Given this list of marker genes USH2A, ZNRF2, PF4V1, PDE4D, DCDC2, CYP2C19, ETS1, NEDD9, MFN2, ADGRL3, ZFYVE28, PPP6R2, BTBD7, C19orf12, LRRC4, PML, MCC, SCN8A, KIF21A, CUL5, LIX1, ZBTB21, E2F6 (NCBI Gene Id 1876), KDELR2, ZBTB20, RAB11FIP2, LMBRD1, LSM8, SKIC3, TMEM132B, ATXN7L1, RBM24, USP42, ASB4, GOLGA4, MBD1, ZNF704, KMT2A, STC2, TNPO1, RINT1, DCUN1D4, TSPAN12, HNRNPF, FRY, ANKRD6, FRS2, RAB3GAP2, NSMAF, TMEM176B, CDKL4, RORA, MYORG, APPL1, SRSF11, ZNF571, BCL11A, PPM1E, SPINT1, GORAB, MAPK9, KHDRBS2, MAP1B, DPYD, DICER1, SSH1, FNIP1, ITGB1BP1, LRRN1, DLL1, RAB33A, RHBDL2, ASH1L, CD1E, KDM5B, CRYBG1, ELK4, ETNK1, BTN3A2, FGFR2, ARMCX3, ZBTB18, BTN3A1, ATP1B2, DPY19L2, UBP1, ANKIB1, TNRC6B, SLITRK4, DCTN6, WDR20, CBFB, YTHDF1, RNF38, JADE1, CDYL2, LDLRAD4, DLEU7, ZNF407, MEF2C, MINDY2, AMOT, PRKACB, GAB1, GPRASP2, CHD6, CREB1, MED26, NEDD4, PJA2, RNF19A, RLN1, DYNC1LI2, RBCK1, MIEF1, CNOT9, PRKAG2, TGFBR3, TMEM74, ZBED1, USP10, ABCB5, DCBLD2, RUBCN, CDK6, TMEM30A, RNMT, NF1, CAB39, TARDBP, KLHL9, VWA8, SMPDL3A, PPP6C, PDE3B, GPCPD1, HSF5, TBKBP1, TENM3, DCDC1, SYNDIG1, WDFY3, NR2C2, PTPN4, WASHC5, SLC25A31, ARGLU1, CRYM, FEM1B, TRIM71, PHF6, VAV3, HIF1A, HECA, TCEANC2 (transcription elongation factor A N-terminal and central domain containing 2), FXR1, TMEM14B, SLC35G1 (solute carrier family 35 member G1), PRR16, BCL2L11, KIF23, EPHA7, GNL3L, PDCL, FGF12, RRAGA, ST13, KLHL21, HOXD9, YAP1, PLS3, PEAK1, GKAP1, SLC9A2, CDC42BPA, UBE2Q1, TSHZ2, BTLA, SMURF2, MYT1L, INIP, ANTXR1, GMFB, PPDPFL, WNT2, KATNBL1, DNAJB4, PABIR2, APOA2, ADK, ANO3, POU2F1, SLC39A10, GPR85, MAP3K9, PRKAB2, HDGFL3, FDX1, KITLG, ABCA5, SEPSECS, VDAC1, SPATA13, EPHA3, CENPL, PPARGC1A, GLT8D1 (glycosyltransferase 8 domain containing 1), PPM1B, TPM3, SETD5, ITPR2, WNT11, TREM1, here is a description of the gene set: from publication Chen Y, Wang X (PMID 31504780) species: Homo sapiens Genes predicted to be targets of miRBase v22 microRNA hsa-miR-7157-5p in miRDB v6.0 with MirTarget v4 prediction scores > 80 (high confidence targets). Human Gene Set: MIR7157_5P